Given this list of marker genes PBXIP1, ARPC2, RPL36AL, PPP1R2, TSC22D3, TUBB4B, CST7, S100A11, ARPC1B, PSMA7, RPL27, MYL6, CYTIP, CRIP1, ATP1B3, ANKRD12, SSR4, TNFAIP3, TRBC1, ARF6 (NCBI Gene Id 63379), RHBDD2, SRGN, SRSF2, SAMSN1, TAGLN2, STK17A, CALM1, ISCU, FYN, SARAF, RPS29 (NCBI Gene Id 6235), CD52, PGK1, RPS27, RGCC, HLA-A, ZFP36L2, HLA-B, CREM, ARHGDIA, LRRFIP1, PRRC2C, RPS10, CD69, S100A4, COX6A1, TRBC2, TPT1, CIB1, EZR, HLA-C, SELENOT, ABRACL, PLIN2, RORA, FXYD5, LAPTM5, TMEM50A, CXCR4, SLC3A2 (solute carrier family 3 member 2), NR3C1, PAIP2, OAZ1, ATP5F1E, SH3BGRL3, EMP3 (epithelial membrane protein 3 (MAM blood group)), MSN, LTB, HLA-E, POLR2L, RHOG, GIMAP7, EIF1, ALOX5AP, FTH1, CD2, PABPC1, PLP2, CORO1A, SUB1, GPR183, RAP1B, ATP6V0E1, IL32, BAZ1A, KLRB1, NDUFB8, IL7R, PPP2R5C, PPP1CB, CD53, RPS21, UBC, RPLP2, TPM3 (NCBI Gene Id 91191), RPL28, STK4, PKM, TANK, CD3D, KMT2E, RPLP1, DUSP2, RPS12, CAST, EML4, TUBA4A, WIPF1, PHLDA1, TRAM1, MALAT1, PTPRC (NCBI Gene Id 5788), BIRC3, RPS16, PFN1, ANXA1, TGFB1, TMSB4X, JAK1, UBB, CDC37, S100A6, FNBP1, UBA52, CD6 (NCBI Gene Id 923), YWHAH, YWHAB, B2M, SPOCK2, RPS26, ARHGDIB, TRAT1, BTG1, HINT1, ISG20, H2AZ2, CLDND1 (NCBI Gene Id 56650), CYBA, CDC42, TSPYL2, AKAP13, PDCD4, CD44, NDUFV2 (NADH:ubiquinone oxidoreductase core subunit V2), TRAC, ITM2A, GLIPR1, CDC42SE2, CD7, CCL5, EVI2B, DDIT4, YPEL5, KLF6, OST4, EVI2A, IL2RG, MRPS6, LEPROTL1, ELF1, CLEC2D, here is a description of the gene set: species: Homo sapiens from publication Fan X, Bialecka M, Moustakas I, Lam E, Torrens-Juaneda V, Borggreven NV, Trouw L, Louwe LA, Pilgram GSK, Mei H, van der Westerlaken L, Chuva de Sousa Lopes SM (PMID 31320652) Human Gene Set: FAN_OVARY_CL12_T_LYMPHOCYTE_NK_CELL_2 The ovaries analyzed showed a pronounced population of CD53high/CXCR4high immune cells (Fig. 2e), including separate clusters for adaptive T lymphocytes and Natural Killer (NK) cells (CL4 and CL12), B lymphocytes (CL18), and innate immune system, such as monocytes and macrophages (CL13)